Given this list of marker genes SRC, CBLL1, CTSS, CTSL, CDH1, RAC1 (Rac family small GTPase 1), FARP2, JUP, CTSB, ELMO1, CTNNA1, VAV2, CTNNB1, UBB, UBA52, CTNND1, CDH11, RPS27A, DOCK1, CDC42, UBC, ARHGEF4, TIAM1, here is a description of the gene set: <p>Early results demonstrated that mutationally activated, oncogenic chicken SRC (SRC-Y527F) activates STAT3 and requires STAT3 activity for neoplastic conversion. Regarding the mechanism, it was later shown that SRC-Y527F increases RAC levels, leading to secretion of IL6, which leads to STAT3 activation. Interestingly however, SRC-Y527F also downregulates cadherins (CDH11 and CDH1), in a quantitative manner, while cadherins are required for the integrity of IL6ST for IL6 family signalling. As a result, SRC-Y527F expression to intermediate levels allows sufficient CDH11, hence IL6ST levels, for STAT3 activation, as previously reported. However, expressed to high levels, SRC-Y527F eliminates CDH11, hence IL6ST signaling, thus eliminating p-Y705-STAT3 entirely.</p><p>Taken together, these data reveal the existence of a loop between SRC, CDH11, IL6/IL6ST and STAT3. This fine balance between SRC-Y527F and CDH11 levels which is required for STAT3 activation and cellular survival, results in an increase (rather than a decrease) in p-Y705-STAT3 in cells with high-chicken SRC-Y527F upon SRC inhibition, a finding which could have significant therapeutic implications regarding inhibitors of activated SRC (Adan, Guy et al. 2022, reviewed in Adan et al. 2022).</p><p>It is interesting to note that a number of oncogenes, such as the membrane-bound, middle Tumor Antigen of the mouse polyoma virus, transform cells through binding to and increasing the kinase activity of the cellular SRC. In addition, it was also demonstrated that nuclear oncogenes such as SVLT (Simian Virus 40 Large Tumor antigen) are also able to activate STAT3, and that SVLT requires c-SRC for oncogenic transformation.</p><p>Interestingly, a cellular STAT3 inhibitor, the Caveolin-1 (CAV1) protein, reduces IL6ST and p-Y705-STAT3 by binding to and sequestering cadherins onto its scaffolding domain. Therefore, it appears that the road to STAT3 is “paved with cadherins”, either to increase, or to decrease, STAT3 activity.</p> Reactome Pathway: SRC activates STAT3 in a quantitative manner, through Cadherin-11 (CDH11), RAC1 and gp130 (IL6ST) species: Homo sapiens part of: Activation of STAT3 by cadherin engagement